The following is a description of a gene set: studied in species Homo sapiens The aggregation, arrangement and bonding together of a set of components to form a mitochondrial respiratory chain complex or between respiratory chain complexes to form high-order structures. Human Gene Set: GOBP_MITOCHONDRIAL_RESPIRATORY_CHAIN_COMPLEX_ASSEMBLY, and this is the list of marker genes: COX16, COA4, ATPAF1, NDUFS2, NDUFC2, COX7A2L, MT-ND5, HIGD1B, TFAM, NDUFA13, UQCRFS1 (NCBI Gene Id 7386), MIURF, NDUFB3, TMEM242, TMEM223, LYRM2, NDUFAF8, TMEM126A, COX18, OXA1L, NDUFA6, MT-ND2, RAB5IF, SDHAF3, UQCC6, LYRM7, UQCC5, NDUFS4, PET117, NDUFAF4, COX20, PET100, DMAC2, SDHAF4, UQCC2 (NCBI Gene Id 84300), SMIM20, SCO1, ATP5F1D, CHCHD4, COA1 (NCBI Gene Id 55744), NUBPL, SLC25A33, COX7A2, NDUFAF3, COX17, HIGD1A, NDUFAF5, NDUFS8, UQCC1, SCO2, MT-ND6, COX7A2P2 (NCBI Gene Id 345363), FASTKD3, NDUFAF2, OMA1, COA6 (NCBI Gene Id 388753), HIGD2A, COA3, SDHAF2, CHCHD7, NDUFS5, ATP23, NDUFAF1, NDUFAF6, TMEM126B, NDUFS6, FOXRED1, TIMM21, BCS1L, COA8, FMC1, TIMMDC1, TTC19, NDUFS1, COX19 (NCBI Gene Id 90639), COX14, HIGD1C, TMEM70, HIGD2B, ECSIT, ATPAF2, UQCC4, IMMP2L, AIFM1, NDUFB2, TACO1, MT-ND1 (NCBI Gene Id 4535), STMP1, FXN, CEP89, NDUFS7, COX7A1, UQCC3, DMAC1, SURF1, COA5, NDUFS3 (NADH:ubiquinone oxidoreductase core subunit S3), ACAD9 (NCBI Gene Id 96656), TMEM186, NDUFAF7, SAMM50, SDHAF1, MT-ND4